Given this list of marker genes Eif2s3x, Eif2b4, here is a description of the gene set: Reactome Pathway: Recycling of eIF2:GDP electronically inferred by orthology from the curated human pathway This event has been computationally inferred from an event that has been demonstrated in another species.<p>The inference is based on the homology mapping from PANTHER. Briefly, reactions for which all involved PhysicalEntities (in input, output and catalyst) have a mapped orthologue/paralogue (for complexes at least 75% of components must have a mapping) are inferred to the other species. part of: Cap-dependent Translation Initiation species: Mus musculus